The following is a description of a gene set: Mouse Gene Set: GOBP_BETA_ALANINE_METABOLIC_PROCESS species: Mus musculus The chemical reactions and pathways involving beta-alanine (3-aminopropanoic acid), an achiral amino acid and an isomer of alanine. It occurs free (e.g. in brain) and in combination (e.g. in pantothenate) but it is not a constituent of proteins., and this is the list of marker genes: Dpys, Dpyd, Aldh6a1, Upb1, Aasdh